The following is a description of a gene set: Transport of mRNA from the nucleus to the cytoplasm, where it is translated into protein, is highly selective and closely coupled to correct RNA processing. part of: Transport of Mature mRNAs Derived from Intronless Transcripts Reactome Pathway: Transport of Mature mRNA Derived from an Intronless Transcript studied in species Homo sapiens, and this is the list of marker genes: NUP43, POM121, CPSF4, WDR33, NUP205, NUP58, NDC1, RAE1, NUP133, CPSF3, NCBP2, NUP155 (NCBI Gene Id 9631), NUP160, NUP210, NUP153, NUP107, NUP42 (NCBI Gene Id 11097), NUP37, TPR, CPSF1, NUP88, POM121C, NCBP1, ALYREF, NUP188, SEC13, NUP93 (NCBI Gene Id 9688), NUP85, RANBP2, NUP54, NXF1, NUP62, FIP1L1, AAAS, NUP50, NUP98, NUP214, SYMPK, CPSF2, EIF4E, SEH1L, NUP35 (nucleoporin 35)